Given this list of marker genes NOL4L, KCNQ1DN (NCBI Gene Id 55539), NFIX, IGF1, LCOR, MAP4K4, HOXB7, DNAJB7 (DnaJ heat shock protein family (Hsp40) member B7), LMO3, NUP62CL, ID4, TMEM209, FAM107B, H3-3A, CNOT4, SPPL3, DNALI1, SLC45A2, CACNA1G, BRCA1, BCL11A, NECAP1, NEUROG2, GNAS, ZCWPW1, FOXA2, FBXW4, SREK1, USP34 (ubiquitin specific peptidase 34), FAM117A, POLG2, SHARPIN, TREX2, PTCHD1 (patched domain containing 1), MTMR3, EMSY, MAF1, RAB5A, HIPK1, EMCN, NAMPT, FOXO4, LRP5, GABARAPL2 (GABA type A receptor associated protein like 2), FAM53B, AFF3, DNAAF6, HAS2, LINC00314, ZC3H6, TBX5, PNMA1, SRSF6, TAPBP, FOXP1, MEPCE, POU4F3, CCNG2, ZBED5, ROBO1, CHTOP, ZMYND8, RBBP6, ACVR2A, RBMS1, EPS8, GNG11, NPVF, IKZF2, CACNA1D, FILIP1, PI4K2A, IKZF3, NBR2, GPR50, PDP1, NKD1, JPT2, CASZ1, TNFRSF8, KCNC2, HOXC11, APC (NCBI Gene Id 324), PRKAG1, PITX2, REPS2, PHF23, MAP4K5, NR2F2, WNT9A, MPPED2, PAPPA, RUNX1 (NCBI Gene Id 861), ANKRD20A11P, CBFB, SGK1, MYO18A, OAZ2, CBX4, PIM2, SUMO4, DLG2, CALM3 (calmodulin 3), HOXB4, ZIC1, LIX1L, ACVR2B, DMTF1, OTX2, FBXL20, FBLN2, LRCH2, TMEM62, KCNMA1, KRT84, HOXB8, JARID2, MSRA, CHM, ANKS1B, WASF2, IL1RAPL1, HEY1, ITGB8 (NCBI Gene Id 3696), CCSER2, HNRNPA0, CTLA4, HOXB6, ZNF362, SALL3, RFX1, ADGRL3, OLA1, CSNK1A1, PDCD4, YPEL5, HOXB3, SRPX, OTP (NCBI Gene Id 23440), SALL2, WFIKKN2, DEDD, FSBP, STAG2, NR2F1, KRT85, EFNB1, NRP2, PIK3R3, HDAC9, FGF12, SIX4, KLF7, PDGFRB, TMEM88, SORBS3, GBF1, SRGAP2, RHEBL1, GABARAP, NTRK2, CADM3, LUC7L3, ACADSB, BMF, KIZ, NFIB, KLF11, RNF122, EFNA1, IRS4, OLFML3, FBXO11, ITGA3, CHMP1B (NCBI Gene Id 57132), LHX6, GTF2A1, ZIC4, TNRC6A, NRXN3, ANKH, IKZF5, DYRK1B, AMELX, EYA4, DSG4, POU4F2, NKX2-2, TCF7L2, GRIK3, SOX5, FGF6, SMARCA2, TBXAS1, CHD6, SLC5A3 (NCBI Gene Id 6526), SEMA3A, TMEFF1, NEUROD2, SLC25A34, ACACA, HJV, SPINK5, PHEX, BLNK, YAE1, RLIM, ICMT-DT, EYA1, NR3C2, NAV3, TMEM187, OTUD5, BARHL1, PBRM1, GDNF, KLF15, METTL26, SLC7A3, CALCOCO1, MEOX1, MNT, SAT1, JUNB, here is a description of the gene set: studied in species Homo sapiens Human Gene Set: FAC1_01 Genes having at least one occurrence of the motif NNNCAMAACACRNA in the regions spanning 4 kb centered on their transcription starting sites. This matches the FALZ transcription factor binding site V$FAC1_01 (v7.4 TRANSFAC).